Given this list of marker genes MEF2C, HDAC1, TGFB2, MYOCD, RADIL, NRG1, SEMA3D, SEMA5B, PITX2, TP53, ZNF281, LTBP3, GATAD2B, MAPK14, PHACTR4, ESR1, UFL1, GDNF, SEMA4G, CTNNB1, PAX2, PHF19, FBXO21, JARID2, SOX9, TACSTD2, FZD1, SLC4A11, SEMA7A, LIF, OVOL2 (ovo like zinc finger 2), TBXT, OCIAD1, CDC42 (cell division cycle 42), FOLR1, GSK3B, EDNRB, GATA6, RBBP7, OTUD5, HES5, PTN, BATF, SOX21, ISL1, EEF1AKMT4-ECE2, ACE, FGF2, EPCAM, CYP26C1, ZFP36L2, CORO1C, LAMA5, ALX1, NDUFS6, YAP1, MTF2, TP63, MTA1, HOXD4 (NCBI Gene Id 50714), DNMT3L, KITLG, PRKDC, SHC4, RBM24, TMSB4X, IFT80, SMO, ARB2A, TWIST1, EDN3, SMAD1, SLC9A1, KBTBD8, LBH, CHD2, PWP1, SETD6, SIX1, CCDC88C, LRP6, HNF1B, WNT10A, SRF, TEAD2, MTA2, SEMA4C, EDN1, EDNRA, BMPR2, HES1, MEOX1, SMYD5, MAPK1, HMGA2, MIR146A, GATAD2A, BMP7, FGFR1, SEMA3E, KRT14, WNT8A, BCL2, SEMA4F, NELFB (NCBI Gene Id 25920), PEF1, NOTCH1, BGLAP, HOXB4, CDK13 (NCBI Gene Id 8621), ERCC2 (ERCC excision repair 2, TFIIH core complex helicase subunit), SEMA3B, HDAC2, SNAI2, SFRP2, ABL1 (NCBI Gene Id 25), LIN28A, SEMA3C, NR5A2, PTPRC, FBXL17, CDK12, EZH2, TBX3 (NCBI Gene Id 91834), MAPK3, SOX17, GREM1, MSX1, PUM1, NUDT21, TRIM6, FGF19, METTL5, SEMA5A, JAG1, EXT1, HIF1A, NRTN, TFAP2C, CITED2, NFE2L2, SIRT6, ITGB1, HESX1, RBBP4, RET, SP7, RPS7, SEMA3F, PDCD6, OSM, HTR2B, MLLT3, NKX2-5, SEMA6A, KIT, WNT3, SFRP1, MBD3, SETD1A, SOX18, SEMA6B, SOX8, KDM3A, MED1, ACVR1, SEMA3A, HSPA9, ENG, FN1, RDH10, A2M, ZEB2, XRCC5, EIF2AK2, SMAD9, MSX2, HAND2, PDGFRA, NOG, MTCH2, SOX10, GPM6A, FOXA1 (forkhead box A1), GBX2, WNT7A, SOX6, NRP1, TTYH1, ITCH, TAL1, BMPR1A, PHOX2B, SETD2, TBX1, REST, MTA3 (NCBI Gene Id 731342), PHF5A, EFNB1, SEMA3G, CDH2, KLHL12, KDM4C, PUS7, SEMA6D, MIR346, CDK6, STAT3, ALDH1A2, NR6A1, SHH, CHD4, RUNX2, SEMA6C, ESRRB, HNRNPU, TBX2, FOXC1, MIR372, TCF15, PSMD11, LMBR1L, SEMA4A, NSUN2, CDX2, SMAD4, DHX36, GSC, CHD3, SEMA4B, DMRTA2, TCOF1, NRP2 (NCBI Gene Id 8828), SOX5, N4BP2L2, BBS12, FOXO4, ELL3, TGFBR2, RBPJ, FGFR2, SEMA4D, L3MBTL2, METTL3, SMAD5, EPOP, NOLC1, ZIC3, PRICKLE1, EOMES, MIR302B, KAT5, CFL1, YTHDF2, SH2B3, TBX5 (NCBI Gene Id 6910), FRZB, TAPT1, BMP4, HOXA7, OSR1, MSI2, FOXC2, ERBB4, PDX1, here is a description of the gene set: The process in which a relatively unspecialized cell acquires specialized features of a stem cell. A stem cell is a cell that retains the ability to divide and proliferate throughout life to provide progenitor cells that can differentiate into specialized cells. Human Gene Set: GOBP_STEM_CELL_DIFFERENTIATION studied in species Homo sapiens